The following is a description of a gene set: Human Gene Set: GOBP_AMIDE_TRANSPORT The directed movement of an amide, any compound containing one, two, or three acyl groups attached to a nitrogen atom, into, out of or within a cell, or between cells, by means of some agent such as a transporter or pore. studied in species Homo sapiens, and this is the list of marker genes: NHERF1, CPLX1, TRPM5, PRKAR1A, GNAZ, ORAI1 (NCBI Gene Id 84876), IRS1, MYRIP, PCLO (NCBI Gene Id 56630), F2RL2, INHBB, CRHBP, CPLX3, AIMP1, PLEKHA8, GNAO1, SIRT6, PLA2G6, MTTP, SNX19, NKX6-1, LRRC8A, CCL5, ILDR1, ABCB9, MAFA (MAF bZIP transcription factor A), SLC25A47, ABAT, FOXO1, TRPA1, PLCB1 (phospholipase C beta 1), ABCA12, PASK, SLC16A1, CAMK2G (NCBI Gene Id 818), SYT7, TM7SF3, C2CD2L, FAM3D, FOLR1, BAD, FAM3B, CAPN10, MMP7, PLTP, MIDN, CHRM3, NNAT, SLC25A42, SSTR5, FGA, SLC25A40, BLK, ABCC1, VIP, ADORA1, PSMD9, SLC14A1, GRP, ABCG2 (NCBI Gene Id 9429), ITPR1, NLGN2, PRKACA, TRPM4, STXBP3, SLC9B2, KLF7, CD38, SRI, TNF, IFNG, SYTL4, FAM3A, SLC16A2, MCU, PRKD1 (NCBI Gene Id 5587), NEUROD1, RAB3A, PFKFB2, RAF1, SGPP1, SLC13A3, SERP1, FGG, CASR (NCBI Gene Id 846), OXCT1, HMGA2, AQP8, MGST1, FOLR2, SIRT3, SLC19A1, PFKM, ACVR2B, MC4R, KCNA5, ENY2 (ENY2 transcription and export complex 2 subunit), HNF1A, FOLR3, C1QTNF12, SIRT4, HLA-DRB1, TOR2A, RAB11FIP2, BMP8A, ANO1, CFTR, GAL, SLC27A1, CHD7, GNA11, TNFSF11, PRKN, PSAP, EDN1, GIPR, ABCA13, SLC5A6, GNAI1, GJA1, RAC1 (NCBI Gene Id 5879), SLC38A3, CCN3, EIPR1, TAP2, TUNAR, PFKL, TCIRG1, UBE2Q1, IL1B, F2RL1, TRH, RAPGEF3, VGF, GPR68, VSNL1, GCK, ABCC8, APLN, ADCYAP1, TARDBP, SLC25A32, EFNA5, F2, BMAL1, UPK3A, UQCC2, HNF4A, TFAP2B, DRD2, PPARD, CLEC4M, RAPGEF4, ACVR1C, FFAR3, RIMS2, CELA2A, SLC38A5, ENSA, GLTPD2, LRP2, HADH, GHRHR, ADRA2C, G6PC2, GNAS, CPT1A, BRSK2, UCP2, INS, SLC25A16 (NCBI Gene Id 8034), NDUFAF2, KCNK16, ABCA1, ZBED6, PTPRN2, SLC15A2, PDPN, RAB1A (RAB1A, member RAS oncogene family), PIM3, FFAR4, ALOX5, RBP4, SLC46A1 (NCBI Gene Id 113235), HNF1B, NMU (NCBI Gene Id 10874), RBM4, SLC30A8, JAK2, DYNLL1, MTNR1B, CYB5R4, SLC15A4, KCNB1, GPR27, PDE8B, CDK16, SREBF1, TRPV4, MLXIPL, EPHA5, GCG, ABCC5, RAB11FIP5, AQP11, GPER1, ABCC4, IRS2, LEP, SCT, SLC33A1, CRHR1, SLC15A3, NADK, PLEKHA8P1, CWH43, PCK2, ABCB4, NOS2, ABCD1, AQP9, SYBU, UCN, ITSN1, PER2, KCNJ11, PARK7, GPRC6A, ACSL4, GHRH, SIDT2, SLC15A1, SLC25A39, DOC2B, NR1H4, ABCB1, ABCA2, NPY2R, SLC25A17, GHSR, SLC25A22, CHGA, UMOD, ECRG4, GHRL, TAP1, MFSD1, GPR119, TACR2, DISP1, SLC7A11, S100A8, STXBP4, SLC16A10, GLTP, TCF7L2, SELENOT, CRH, CCDC186, SMAD2, GLUD1, PDX1, FOXA2, GIP, GABBR1, TRPV1, PTPN11, FFAR2, RASL10B, CDH17, CLN3, RFX6, NR1D1, CLTRN, EXOC3L1, AACS, CPE, PRKCE, SMPD3, LRP5, SLC14A2, EDN3, NPFF, CD74, IL6, PICK1, AQP1, TFR2, STX1A, ABCD2, PAX8, JAGN1, ADCY8, RAB11B, IL1RN, SOX4, REST, ISL1, RPH3AL (rabphilin 3A like (without C2 domains)), OSBP, POU3F3, NR0B2, SLC2A2, CPTP, SLC8B1, ADCY5 (adenylate cyclase 5), PTPRN, ADRA2A, HFE (homeostatic iron regulator), VAPA, HIF1A, RFX3, CERT1 (NCBI Gene Id 10087), AQP3, PRKCB (NCBI Gene Id 5579), MPC2, RAB8B, CA2, SLC26A6, ILDR2, CD209, PPP3CB, FKBP1B, SLC19A2, CARTPT, CLOCK, BAIAP3, FGB (NCBI Gene Id 2244), PHPT1, HTR2C, PRKCA, SNAP25, SLC15A5, GPLD1, UCN3, FFAR1, STX4, AQP7